Given this list of marker genes Cdk9, Eaf2, Ell, Nelfb, Ccnl1, Tex24, Supt4b, Ccnk, Nelfcd, Rtf1, Supt6 (SPT6, histone chaperone and transcription elongation factor), Paf1, Tonsl, Mllt3, Nufip1, Elof1, Cdk13, Mms22l, Ssrp1, Aff3, Elob, Eloa, Pex2, Zc3h8, Elp4, Supt5, Ercc6, Epop (NCBI Gene Id 217147), Snw1, Ell2 (elongation factor for RNA polymerase II 2), Aff2, Elp2, Cdk12, Mllt1, Rb1, Aff1, Ccnt1, Nelfa, Brd4 (NCBI Gene Id 57261), Eaf1, Aff4, Supt16, Cdc73, Elobl, Ice2, Ctr9, Skic8, Ccnt2, Leo1, Eloc, Ice1, Supt4a, Nelfe, Ell3, here is a description of the gene set: species: Mus musculus Any protein complex that interacts with RNA polymerase II to increase (positive transcription elongation factor) or reduce (negative transcription elongation factor) the rate of transcription elongation. Mouse Gene Set: GOCC_TRANSCRIPTION_ELONGATION_FACTOR_COMPLEX